The following is a description of a gene set: species: Homo sapiens Human Gene Set: EGR2_01 Genes having at least one occurrence of the motif NTGCGTRGGCGK in the regions spanning 4 kb centered on their transcription starting sites. This matches the EGR2 transcription factor binding site V$EGR2_01 (v7.4 TRANSFAC)., and this is the list of marker genes: NRGN, GABRQ, TFAP4 (NCBI Gene Id 7023), TBC1D10A, RIMS1, SYNCRIP, GSX1, NUP107, ARPP21, RELA, SH3GL3, PLXNC1, SRF, SEC14L1, LGI1, KCNJ1, RRBP1, VTN, TAF11, SOX4, COL26A1, NAB2, POLR1G, DCAF7, WDR48, PKD1, SUMO2, SERTAD1, DVL2, UBASH3B, NRCAM, VASH1, CLTC, XPR1, PABIR2, ZNF575, UBXN10, SRRM4, EIF3B, ITPR1, CX3CL1, CFL1, RAPGEFL1 (NCBI Gene Id 51195), BMPR2, PLPPR1, ZCCHC14, FSHB, CSTF3, XK, CD40LG, EPHB3, KIF1C, LMNTD2, VEGFA, UBE2W, BCL6, DYNLL1, COLEC12, NKX2-2, MACROH2A2, ATOSB, SPTB, THPO, ANKH, SORCS3, GNL1, PRKCE, PTPN7, NOP53, BCL2A1, HMGN2, FUS, GPR132, CNOT9, SSTR3, CREBRF, ANKS1A, GPC4, SLC25A39, DNASE1L2, CMAS, RALYL, KCNH3, ITPKA, AKAP10, HDAC9, ZHX2, HMG20B, OSR1, RALGPS2, GABRA1, DSCAM, KREMEN2, PABPC4, ERF, RASSF7 (Ras association domain family member 7), KCNQ5, DIAPH1, AP1S1, FBXL20, FBXL19, PNCK, PDGFB, INCA1, PRR3, SMAD1, NFATC3, CA11, VGF, PDCD6IP, KCNB2, HOXB6, MNT, AHNAK, KLF5, SMARCA5, PPP1R1B, UPRT, C9orf72, MAN2A2, SNAP25, PRKAG1, MRC2, PTGES, MASTL, MED14, THRA, RERE, FRA10AC1, WWP2, SCAI, ATP2A2, SUN2, ERGIC3, LMTK2, L1CAM, GNAI2, DOC2A (double C2 domain alpha), MYB (NCBI Gene Id 4602), DES, IGF2BP1, SIRT1, HNRNPDL, EGR3, SCN5A, RBBP6, ETV4, SIN3A, BAHD1 (NCBI Gene Id 22893), CAMK2A, CSRNP1, MAP3K3, CHRD, RTL3, USP37, SMYD5, GSE1, CELF4, ESRP2, MAP1A, HOXA3, NDUFA4L2, RUNX1, HRK, TP53I11, ZNF281, SH3BP1, PDZD7 (NCBI Gene Id 79955), DLK2, FASLG, KCNIP2, AK2, PRRC1, PTCHD1, PDGFRB, KLF4, SARM1, MSL2, ITGB8, ATL1 (NCBI Gene Id 6681), RHBDL3, EGR1, PCOLCE, SYVN1, GUCY1A2, USP4, WDR44, EPHB1, YME1L1, CDKN2C, SRCIN1, GPRIN3, WNT1, ADAMTS15, ATP6V1C1, CGGBP1, SSTR1, ADGRB3